The following is a description of a gene set: species: Homo sapiens Catalysis of the transfer of an aldehyde or ketonic group from one compound (donor) to another (acceptor). Human Gene Set: GOMF_TRANSKETOLASE_OR_TRANSALDOLASE_ACTIVITY, and this is the list of marker genes: TKT (NCBI Gene Id 7086), ILVBL, TKTL1, TKTL2, TALDO1